The following is a description of a gene set: The area of a motile cell closest to the direction of movement. Human Gene Set: GOCC_CELL_LEADING_EDGE species: Homo sapiens, and this is the list of marker genes: CORO1C, ILK, MYH9, S100A6, HCN2, KCNC2, ABI2, PDE9A, ACTA1, ADGRV1, RAB22A, PLEKHO1, ANTXR1, ADAM17, CD177, TUBB3, HIP1R, SPEF1, ARAP1, ACTR3, SWAP70, MYADM, TIRAP, SH3BGRL3 (SH3 domain binding glutamate rich protein like 3), ARHGEF4, NHS, MYO1C, ACTC1, TRPV1, EEF1A1, CARMIL2, SPATA13, CASP8, FGD4, PSD2, LDB1, VIM, UNC5C, PDXP (NCBI Gene Id 57041), CIB1, ABLIM3, ITGB1, EPB41L3, FAM89B, ATP2B2, NME2, PLEK2, CXCR4, CORO1B, THY1, CTTN, TESC, PXN, KCNN4, LCP1, BMX, CLIP1, PAFAH1B1, FGD3, SLC12A5, ARHGAP31, EPS8L3, CDK5, KLHL41, WASF3, PKHD1L1 (NCBI Gene Id 93035), RAB13, ARF6, FIGNL2, WASL, AKT1, SRGAP2, DDN, PTPRJ (protein tyrosine phosphatase receptor type J), ARF4, RASGRP2, KITLG, ARHGAP1, SLC9A1, SAMSN1, DUOXA1, KANK1 (KN motif and ankyrin repeat domains 1), TRPV4, CDC42BPA, GSN, FGR, ARHGAP18, SCIMP, TPM1, EPS8, GRIA1, ARPC2, ACTB, INPP5E, CLCN3, PLCG1, GABRG1, PTPRO, IGF2BP1, OCLN, APPL2, ITGB1BP1, STON1, ABI1, DOCK8, SH2D3C, ROCK1, ATP6V1B2, ARHGEF26, CLASP2, SNTG1, IQGAP2, CSPG4, VEZT, MEFV, TMEM87A, MYO6, GNAS, GABRA2, IFIT5, ITGAV, MPP2, ANK1, CCDC88A, ARAP3, APC, MYO5A, ACTA2, PACSIN1, PAK1, PABPC1, WWC1, PRKCI, PLCE1, SH3BP1, CLRN1, NF2, CTNNA3, SH2B2, DUOX2, ARFIP2, PIK3CA, ARHGAP45, APBB1IP, DAGLA, INPP5J, FERMT2, SSX2IP, ITGB4, CTNNA2 (NCBI Gene Id 1496), KLHL2, ABLIM1 (actin binding LIM protein 1), CFL1, PPP1R9B, TLN1, MTM1, SHTN1, SHISA7, DAG1, DCTN1, INPP5K, KCNC4, UNC5A, P4HB, GABRE, KDF1, EZR, DST, CAPZB, CNTNAP2, PIP5K1C, ARPC3, TRPM7, FER, PODXL, TNFRSF12A, CORO1A, LIMA1, ERBB2, ALS2, GABRG3, RASA1, PTPN13, RIPOR2, OPRD1, ENAH, EPS8L2, GABRA3, RUFY3, TWF2, RAPGEF3, C2CD5, PLA2G4F, ROBO2, ARPIN, GABRA5, ADGRE2, CLRN2 (NCBI Gene Id 651058), SNX9, DUSP22, STX2, CYFIP1, ACTN1, HPCA, WASF1, SGCE, LAMP5, APC2, CAPRIN1, CDK6, SYNE2, S100B, EVL, CD44, DIAPH1, VIL1, KNSTRN, FAP, DGKZ, FGD1, PSTPIP1, CDH1, ATP6AP2, SSH1, IQGAP1, RAC1, RAC3, VASP, MACF1, SNX5, SLC9A5 (NCBI Gene Id 6553), DLC1, MTMR9, RPS3, SNX2, SLK, AAK1, FERMT1, CTTNBP2NL, USH2A, ARPC5, BRK1, PSD, CDC42, LIMK1, APP, PHACTR4, PHPT1, EGFR, RINL, FSCN3, NCKAP1, RHOA, PEAR1, MYO1D, LAYN, CACNG8, ACAP2 (NCBI Gene Id 23527), MYLK, ARHGEF6, AIF1L, ABL1, CADM4, NHERF1, PLEKHA1, PDLIM7, MTSS2, SPRY2, PLXND1, PHLDB2, JCAD, DPYSL3, KCNC3, SHISA8, AMOT, SLC1A2, ITSN1, HAX1, BAIAP2, NEDD9, RIGI, ABITRAM, GABRG2, KCNB1, CYTH3, CLCN2, GABRA6, DPP9, GDPD2, MTSS1, ITGB3, RAB34, INSR, MYO10, CDC42BPB, PDLIM4, INPPL1, HDAC6, PSD4, SPRY4 (sprouty RTK signaling antagonist 4), AMPH, GABRA1, PKN2, DPP4, DBNL, LDB2, PTK2B, TIAM2, PLEKHH2, MTMR6, EPS8L1, APBB2, SHISA9, MYO1G, BLOC1S6, MAPT, BCAS3 (NCBI Gene Id 89751), PTPRM, SPTBN1, TLN2, CTNNB1, PTPRK, GIT1, JMY, COBL, TWF1, SH3RF1, ADORA2A, STX4, GABBR1, AIF1 (allograft inflammatory factor 1, NCBI Gene Id 9471), FRMD4B, PIEZO1, CDKL5, MKLN1, PARD6A, STX3, CD2AP, FGD6, PSD3, RNH1, PLEKHG5 (pleckstrin homology and RhoGEF domain containing G5), TACR3, CAPG, RAC2, SLC39A6, PDE4A, STMN2, RAB5A, KCNA2, CDC42BPG, PIP5K1A, AVIL, CTNNA1, ITGA8, FSCN1, FLOT1, KCNC1 (potassium voltage-gated channel subfamily C member 1), SRC, WASH3P, TSC1, EPHA2, PARVB, ADORA1, SHISA6, LMO4, PACSIN2 (NCBI Gene Id 150377), CARMIL1, EPB41L5, DUOXA2, BCAR1, MYO9B, ABCA7, KPTN, PLEK (pleckstrin), WIPF1, PALLD (palladin, cytoskeletal associated protein), TUBG1, SH3YL1, HCN1, RAPH1, ASAP3, AKT2, WASF2, MYH10, GABRA4, SORBS2, FLOT2, SCYL3, PLCG2, CDH2, KSR1, VAMP7, AKAP5, MTMR14, FAM107A, TESK1 (NCBI Gene Id 7016), ARHGEF2, ARHGAP44, RIPOR1, CARMIL3, APPL1, ARF1 (NCBI Gene Id 375), PTK6, AJUBA (NCBI Gene Id 84962), THEM4, FAT1, GBF1 (NCBI Gene Id 8729), DUOX1, ACTG2, GPER1, SCRIB, ABI3, DDX3X, RDX, FGD5, PKD2, ARHGEF7, S100A11, FGD2, SNX1, NDEL1, RAB3IP, MCC, PDPN, ANGPTL3, NME1, APBB1, ATF4, TLR4, KIF18A, ITGA5, NRBP1